Given this list of marker genes Mapk1, Gabra2, Sigmar1, Rps3, Itgb3, Prr12, Rpl23, Syap1, Gpm6a, Slc6a4, Mettl5, Dpysl2, Lrrtm1, Myl7, Psmc5, Plat, Ppp1r9b (NCBI Gene Id 217124), Ap2m1, Rpl36a, Pik3c3, Shroom4, Sos1, Rgs9, Lrrk2, Mtmr2, Ppp1r9a, Prkcz (protein kinase C, zeta), Lin7c, Rapgef2, Cltc, Lrrtm4, Rpl31, Stx12, Kcnb1, Rgs14, Nsg2, Fxr2, Itpka, Eif4g1, Dlgap3, Il1rapl1 (interleukin 1 receptor accessory protein-like 1), Lnx1, Nlgn1, C1qc, Fyn, Parn, Cacna1e, Gapdh, Tenm2, Srgap3, Atp1a2 (NCBI Gene Id 98660), Igf1, S1pr2, Hnrnpk, Rpl6, Utrn, Prkaca, Vhl, Ptpn1, Kcnd3, Psen1, Trim47, Tnik, Dmtn, Erbb2 (erb-b2 receptor tyrosine kinase 2), Kcnc1, Eif4ebp2, P2rx3, Rpl27, Syn1, Cntnap2 (NCBI Gene Id 66797), Kif5a, Begain, P2rx7, Prrt2, Abl1, Rgs7bp, Rusc1, Ywhaz, Cpeb4, Gnb5, Dbnl, Sorcs3, Lzts1, Grid2ip, Rps12, Arrb2, Cbln1, Rab4a, Map1a, Grik4, Lrrtm3, Frrs1l, Cacng7, Wasl, Arc, Kif17, Mecp2, Kctd8, Limk1, Slc17a7, C9orf72, Tfrc, Slc16a3, Filip1, Elavl1, Aplp2, Chrna9, Add2, Dlg1, Caly, Plcb1, Rbmx, Tnk2, Src, Rnf19a, Rhog, Drosha, Itpr1 (NCBI Gene Id 18544), Rpl10, Cast, Prickle1, Actn4, Abhd17a, Casp3, Gper1, Fam81a, Sema4c, Trim3, Chrm5, Robo2, Baalc, Gphn, Stau2, Map1b, Fxyd6, Abr, Rps27rt, Olfm2, Rps6kb1, Kif5b, Gabra4, Zdhhc5, Hspa8, Gabra1 (gamma-aminobutyric acid type A receptor subunit alpha 1), Rtn4, Chrne, Rasgrf2, Canx, Gopc, Abl2, Flna, Chmp4b, Htr7, Flrt3, Mapk8ip2, Adra1a, Sri, Igf2bp1, Anp32e, Chrm1, Grid2, Phb1, Rnf220, Pcdh10, Atp1a1 (ATPase, Na+/K+ transporting, alpha 1 polypeptide), Tsc2, Asap1, Dok7, Ptch1, Aldoc, Drd1, Adra2a, Grin2c, Pcdh8, Arhgef7, Oprk1, Rpl9, Nptn, Senp7, Baiap2, Grin2a, Mtor, Zdhhc17, Chrna3, Syt11, 4930544G11Rik, Hnrnpa3, Dstn, Agap2, Mpp2, Kcna1, Slitrk2, Mob4, Gabrg1, Ryk, Nrcam, Gabrq, Ppfia1, Mib1, Fbxo45, Zdhhc15 (zinc finger, DHHC domain containing 15), Crkl, Grm6, Gabre, Rpl21, Ngdn, Sumo3, Celf4, Stx3, Nlgn3, Grm1, Stx1a, Clmp, Camk1, Pdlim4, Wnt5a, Magi2, Add1, Itga8, Myo9a, Arhgef2 (NCBI Gene Id 99482), Espn, Kcnn2, Nck2, Nlgn2, Abhd17c, Rims1, Kcnma1, Itga5, Clta, Dbn1, Gabbr1, Zdhhc2, Pdpk1, Strn, Ncs1, Nrgn, Rpl35, Gsk3b, Crtc1, Homer1, Dip2a, Psen2, Chrnb2, Pkp4 (plakophilin 4), Chrm2, Apc2, Rpl18a, Rhoa, Lasp1, Rps27, Hnrnph1, Grik3, Gnao1, Kcnd1, Iqsec3, Syn3, Rpl15, Dag1, Sema4b, Fmnl2, Ppp1r1b, Gpr156, Lhfpl4, Magee1, Arhgap44, Gipc1, Rps25, Itgb1, Gabrg3, Dvl1, Prkar2b, Nos1, Apbb1, Hnrnpa2b1, Wasf1, Glra3, Grip1, Ror2, Crmp1, Igsf21, Tmem240, Faim2, Pura, Trpv1, Pin1rt1, Sema4d, Grk3, Ncoa2, Snx6, Slc1a3, Prkar1b, Atp2b2, Rps21, Napa (NCBI Gene Id 67002), Rps19, Ube3a, Susd4, Gabrr1, Col13a1, Gabrb3, Adcy8, Rpsa, Hip1, Rnf216, Grm5, Nsg1, Adam10, Atp7a, P2rx6, Cpsf2, Clcn2, Slc12a5, Fxr1, Ank1, Capzb, C1qb, Htr3a, Mapt, Cul3, Myo9b, Atp2b1, Grin2b, Gabrb2, Pde4b, Cspg5, Slitrk3, Kcnj4, Hnrnph2, Mark1, Slc29a1, Drd5, Igsf9b, Mapk10, Afdn, Htt, Pdxp, Slc6a11, Camk2b (calcium/calmodulin-dependent protein kinase II, beta), Map2k1, Mylk2, Frmpd4, Plekha5, Ppp1ca, Tacc3, Stat3, Asic1, Chrna1, Eps8, Met, Exoc4, Bdnf, Eif3a, Kcnk2, Psd, Sh3glb2, Calr, Chrna2, Eif4ebp1, Eef2k, Nedd4, Bcr, Rpl38, Arrb1, Cdh1, Ap2s1, Kcnj6, Strn3, Pak2, Lrrc4c, Tmem108, Prrt1, Pcbp2, Slc8a3, Nectin3, Gabbr2, Picalm, Cdh10, Rab3a, Akap1, Sh3gl1 (SH3-domain GRB2-like 1), Clcn3, Sumo1, Snta1, Shisa7, Tspan7, Rps28, Rab3gap1, Nlgn4l, Gabra3, Slc6a3, Ncam1, Cadm1, Rps2, Praf2, Dock1, Drd2, Nos1ap, Cpt1c, Ppp1cc, Cdk5r1, Rab17, Hnrnpd, Cnksr2, Cit, Kif21b, Dynll2, Pin1, Sorcs2, Map2, Septin7, Clstn2, Eif2b2, App, Ank2, Inpp4a, Lpar1, Camkv, P2rx4, Smcr8, Chrna7, Rps11 (NCBI Gene Id 27207), Rab11fip5, Usp50, Kcna3, Cacna1h, Ptprs, Slc6a17, Snap47, Rpl35a, Abi1, Rps24, Tanc2, Gpr158, Cttn (cortactin), Nptx2, Elfn1, Arpc2, Mef2c, Numb, Pfn2, Arhgef9, Fcgr2b, Adgrl2 (adhesion G protein-coupled receptor L2), Ngef, Ncdn, Cd3e, Neto2 (neuropilin (NRP) and tolloid (TLL)-like 2), Dlgap4, Fgf7, Palm, Dlg5, Slitrk5, Glrb, Grin3a, Pak1, Gpr50, Ache, Ghrl, Fam107a, Pak3, Wwc1, Pcdhb16, Flrt2, Rps23, Rpl5, Gpr179, Nrp2, Shisa9, Rpl13, Hap1, Arhgap39, Whrn, Kalrn, Caskin1, Rpl7, Dnm1l, Cpeb1, Slc1a6, Kifap3, Syt17, Slc8a1, Cap1, Bin1, Capn2, Notch1, Mir132, Srgap2, Cacng3, Rpl26, Ube2i, Faah, Vps52, Oprm1, Tsc1, Slc18a2, Rps15a, Mkln1, Nrp1, Gabrg2, Rpl37, Chrnb1, Dcc, Kcnc3, Sptbn1, Sh3gl3, Rab8a, Kcnc2 (potassium voltage gated channel, Shaw-related subfamily, member 2), Fbxo2, Ago2, Braf, Disc1, Fgfr1, Dclk1, Rpl14, Prmt8, Git1, Lrrtm2, Epb41l3, Grin1, Rpl23a (ribosomal protein L23A), Mir134, Abi2, Igsf9, Kif2c, Scn8a, Camk2d, Htr4, Chrna5, Dmd, Glra1, Actn2, Rpl36, Hspb1 (NCBI Gene Id 15507), Rpl28, Necab2 (N-terminal EF-hand calcium binding protein 2), Senp5, Rph3a, Tacr1, Yes1, Rpl24, Dst, Shc4, Hip1r, Cacnb1, Gria4, Apba1, Snx27, Psd2, Abhd6 (abhydrolase domain containing 6), Cyp46a1, Napepld, Adgrb1, Kcna4, Rnf112, Kcnt1, Cpeb3, Htr3b, Gabrd, Carmil3, Arf4, Ophn1, Epn1, Gabra5, Pfn1, Sipa1l3, Fgf22, Adgrb3, Rgs10, Dtnb (NCBI Gene Id 13528), Macf1, Efnb3, Pum2, Grk2, Dnm3, Cald1, Lama2, Mpdz, Hnrnpab, Als2, Vangl2, Anks1b (ankyrin repeat and sterile alpha motif domain containing 1B), Igsf11, Lin7b, Actr3, Fmr1, Dlgap2, Caprin1, Elavl4, Gria2, Brsk1, Fcho1, Grip2 (glutamate receptor interacting protein 2), Cacna1s, Dgki, Chrm4, Cblb, Hnrnpm, Adora1, Rps6kc1, Akap5, Arf6, Ube2m, Grik1, Dgkq, Sharpin, Snx14, Slc16a7, Rps18, Kif5c, Sptan1, Map4, Kpna2, Nr3c2, Snca, Vasp, Cdk5, Erbb4, Chrng, Kif3a, Atxn1, Sema4f, Mdm2, Musk (muscle, skeletal, receptor tyrosine kinase), Rnf10, Iqsec1, Rpl10a, Lzts3, Ctnna2, Lrrc4b (leucine rich repeat containing 4B), Dicer1, Rplp1, Kcnd2, Zdhhc12, Eea1, Ddn, Icam5, Cript, Grik5, Ntrk2, Grid1, Cplx1, Dnm2, Stxbp1, Psmc2, Tent2, Tiam1, Atp1a3, Rpl8, Lats1, Iqgap1, Myh10, Actr2, Tanc1, Akap9, Pias3 (protein inhibitor of activated STAT 3), Npas4, Slitrk1, Dlg2, Syngap1, Lrfn5, Ap2a2, Cyth2, Rps13, Gnaq, Lrp8, Iqsec2, Dlgap1, Pip5k1c, Cyp19a1, Adora2a, Adgra1, Rac3, Grin2d, Pcdh17, Neurl1a, Nefm, Rps20, Shank2, Gabrr3, Pten, Lrrc7, Ntrk3, Lrfn3, Acp4, Rps3a1, Thy1, Sptbn2, Arf1, Csmd2 (CUB and Sushi multiple domains 2), Dlg3, P2rx2, Nr3c1, Dnajc6, Sh2d5, Bnip3 (NCBI Gene Id 12176), Chrna10, Cdc42, Palmd, Lyn, Snap23, Zzef1, Gsg1l, Elmo1, Cacng8, Myo5b, Snap91, Rps16, Dock4, Lrfn4, Ephb2, Rpl29, Senp1, Ctnnd2, Epha4, Kctd16, Adcy1 (NCBI Gene Id 52867), Strn4, Arhgap32, Dapk1 (death associated protein kinase 1), Rab5a, Rpl37a, Kpna1, Prkn, Gabrb1, Insyn1, Cacng4, Gria1, Cadps2, Zdhhc8, Nbea, Kcnj2, Abi3, Ube3b, Add3, Pdyn, Psd3, Dnajb1, Tppp, Nckipsd, Chrnb4, Atg5, Lin7a, Cnih3, Neto1, Kif1b, Kcnab2, Dixdc1, Apc, Atad1, Cdh2, Dagla, P2ry1, Rab11fip3, Rps14, Lck, Itsn1, Zc4h2, Sspn, Slc1a1, Comt, Rab11a, Klhl17 (NCBI Gene Id 231003), Rps17, Dgkb, Sh3gl2, Asic2, Plcb3, Grin3b, Vdac1, Snx1, Cnn3, Adra2c, Trio, Kcna2, Oprd1, Adgrl3, Myo6, Shank1, Rapgef4, Igf1r, Homer2, Pcbp1, Synpo, Nedd4l, Actb, Ghsr, Slc9a5, Rps10, Grm2, Ppp1r2, Eif4e, Uba52, Ap3m1, Slc4a10, Ctnnb1, Drd3, Gapdhrt2, Grm7, Dgcr8, Erbin, Slc6a9, Cdh9, Clstn1, Bcl11a, Gna13, Epha7, Kcnc4, Rtn3, Pak6, Zfp804a, Rps5, Rpl32, Rpl34, Glra4, Rpl4, Tmub1, Aurka, Sptb, Napb, Nr1d1, Plxnb1, Apba3, Rgs7, Abhd17b, Olfm1, Hcrt, Lrfn2, Clstn3, Syt1, Ckap5, Mark2, Syn2, Syp, Pick1, Ppp3ca, Usp48, Rplp0, Ap2a1, Cap2, Rpl12, Bsn, Arfgap1, Zmynd8, Syt3, Cntn1, Farp1, Septin11 (NCBI Gene Id 67780), Shisa8, Cfl1, Cacna2d1, Kctd12, Pacsin1, Samd14, Ube2n, Gabrr2, Amot, Ap3d1, Mink1, Ppfia2, Kif3b, Nefh, Cyfip1, Lrfn1, Apba2, Ogt, Rpl7a, Prkcd, Sez6l, Actg1, Scrib, Pclo, Chrna4, Abi3bp, Cd200, Slc30a1, Sez6, Cdkl5, Efnb2, Rps26, Ptprt, Chrna6, Myo5a, Arhgef15, Ptn, Slc1a7, Rpl17, Lrrc4, Grik2, Gria3, Erbb3, Cacng5, Camk2g, Sipa1l1, Rims3, Kif1a (NCBI Gene Id 403189), Arfgef2, Rtn2, Ptprz1, Gng3, Appl1, Slc1a2, Rps27a, Rheb, Crhr1, Htr2a, Tamalin, Rpl27a, Phb2, Eif4g2, Cryab, Slc6a1, Prr7, Negr1, Nsmf, Dtnbp1, Vps35, Taok2, Ina, Cplx2, Nckap1, Slc6a6, Cacna1a (calcium channel, voltage-dependent, P/Q type, alpha 1A subunit), Actn1, Hpca, Rmdn3, Ddx3x, Slc6a8, Pgr (progesterone receptor), Slc24a2, Atp6ap2, Slc8a2, Dnaja3, Calb1, Dact1, Gapdhrt, Camk2a, Rps7, Glra2, Gripap1, Swap70, F2r (coagulation factor II thrombin receptor), Chrm3 (NCBI Gene Id 12671), Wasf3 (NCBI Gene Id 245880), Jak2, Kptn, C1qa, Srcin1, Usp8, Epb41l1, Atr, Rpl30, Plppr4, Vwc2, Chrnb3, Fus, Nrg1, Gabra6, Hcn1, Syndig1, Lrp4, Camk4, Nefl, Kcnh1, Crtac1, Cacng2, Dock10, P2rx1, Shank3, Sh3kbp1, Chrnd, Pdlim5, Elfn2, Ppp3r1, Ptk2, Shisa6, Celsr3, Rpl22, Cntn2, Drp2, Fzd9, Camk2n1, Pias1, Arhgap33, Spock1, Cabp1, Itga3, Eif3e (NCBI Gene Id 16341), Prnp, Ngfr, Itgb4, Rpl13a (ribosomal protein L13A), Mt3, Dgkz, Egln1, Syne1, Neo1, Rplp2, Plcb4, Gpsm2, Rtn1, Htr5a, Ptpro, Ctnnd1, Lrp1 (NCBI Gene Id 16971), Gap43, Ntsr1, Prickle2, Sumo2, Mir99a, Homer3, Cnih2, Rac1 (Rac family small GTPase 1), Bmpr2, Adrb2, Map3k7, Vezt (NCBI Gene Id 215008), Ptchd1, Cacna1c, Ptprf, Pja2, Trappc4, Cttnbp2, Chmp2b, Fabp5, Dlg4, Drd4, Senp6, Stx4a, Usp9x, Ptk2b, Rps9 (NCBI Gene Id 76846), Ap2b1, Erc1, Vps26b, Ank3, Rock2, Marcks, Ablim1, Prkcg (protein kinase C, gamma), Rapsn, Insyn2a, Grm3, Adam22, here is a description of the gene set: The part of a synapse that is part of the post-synaptic cell. Mouse Gene Set: GOCC_POSTSYNAPSE studied in species Mus musculus